Given this list of marker genes KRAS, PIK3CA, STAT5B, PIK3R1, NOX4 (NCBI Gene Id 50507), MYO18A, ETV6, TRIP11, GRB2, SPTBN1, SOS1, HRAS, GOLGB1, PIM1, ZMYM2, STAT5A, CDKN1A, NRAS, GAB2, here is a description of the gene set: Reactome Pathway: Signaling by FLT3 fusion proteins part of: FLT3 signaling in disease species: Homo sapiens In addition to internal tandem duplications and activating point mutations, FLT3 is also subject at low frequency to translocations that generate fusion proteins. These fusion proteins occur in some chronic myeloid leukemias as well as myeloid neoplasms with eosinophilia, and generate constitutively active proteins by virtue of fusing a N-terminal partner encoding a dimerization domain with the intracellular region of FLT3. To date, 6 fusion partner genes of FLT3 have been identified: ETV6, TRIP11, MYO18A, SPTBN1, GOLGB1 and ZMYM2.